The following is a description of a gene set: Human Gene Set: GOBP_NEGATIVE_REGULATION_OF_CELL_MIGRATION_INVOLVED_IN_SPROUTING_ANGIOGENESIS studied in species Homo sapiens Any process that decreases the frequency, rate or extent of cell migration involved in sprouting angiogenesis. Cell migration involved in sprouting angiogenesis is the orderly movement of endothelial cells into the extracellular matrix in order to form new blood vessels contributing to the process of sprouting angiogenesis., and this is the list of marker genes: MIR494 (NCBI Gene Id 574452), MIR885, MIR26A1, TBXA2R, MIR16-1, MIR503, MIR29C, MIR2355, MEOX2 (NCBI Gene Id 4223), MIRLET7A1, CARD10, MIR149, MIR221, KLF4, MAP2K5, NOTCH1, MIR15A, MIR495, MIR361, MIR206, MIR329-1, MIR205, MIR424, MIR193A, SPRED1, THBS1, MIR497, MIR196A1, PDCD10, ITGB1BP1, MIR483, MIR19B1, MIR320A, RHOA, MIR20A, MIR146A, MIR22, MMRN2, MMRN1, DLL4, HDAC5, MIR410, MIR200C, STARD13, MIR199A1